The following is a description of a gene set: from publication Chen Y, Wang X (PMID 31504780) Genes predicted to be targets of miRBase v22 microRNA mmu_miR_1930_5p in miRDB v6.0 with MirTarget v4 prediction scores > 80 (high confidence targets). studied in species Mus musculus Mouse Gene Set: MIR_1930_5P, and this is the list of marker genes: Eya1, Aff4, Tbx3, Arhgef25, 1700028K03Rik, Mgll, Ddx6, Pld6, Galnt14, Slmap, Trappc4, Zfp941, Bicral, Asph, Cyp4f39, Dmxl2, Atl2, Ifitm10, Slc4a4, Myo9b, Trpa1, Epdr1, Zfp976, Fbxl14, Apba1, Plxdc2, Arhgef33 (Rho guanine nucleotide exchange factor 33), Iqsec3, Crebl2, Zfp937, Carnmt1, Zfp9, Rnf20, Cacybp, Fads1, Il36rn (interleukin 36 receptor antagonist), Yipf6, Galnt7, Nrg3, Pdia4, Eif4g3, Hdx, Ccdc171